The following is a description of a gene set: Any process that modulates the frequency, rate or extent of the assembly of actin filaments by the addition of actin monomers to a filament. species: Homo sapiens Human Gene Set: GOBP_REGULATION_OF_ACTIN_FILAMENT_POLYMERIZATION, and this is the list of marker genes: ELN, SPTBN2, BBS4, CYFIP1, SCIN, CDC42EP1 (CDC42 effector protein 1), FLII, MYADM, TENM1, EVL, CYFIP2, TMOD1, FCHSD2, CAPZA2, ADD2, KANK1, SNX9, DMTN, TWF2, NCKAP1, RAC1, BIN1, ABITRAM, NPHS1, PLEKHG2, ESAM, RASA1, TRIOBP, HCK, BAG4, HCLS1, FER, SSH2, CORO1A, ARHGAP28, CDC42EP2 (NCBI Gene Id 10435), ARPC5L, TMSB4X, MKKS, CAPZB, HIP1R, CAPZA1, NCK2, SPTBN4, SVIL, PRKCD, ARHGAP18, SPTBN1, CCR7, SSH1, MTOR, CARMIL1, LATS1, TWF1, HAX1, CCL26, BAIAP2L2, NCKAP1L, CCL24, ADD3, PFN2, TMOD4, NCK1, CCL21, LMOD3, WASHC2C, SLIT2, PYCARD, KANK4, LMOD1, CYRIB, GBA2, CRACD, ARF6, ARPC5, MTPN, PFN1, C15orf62, CARMIL2, BAIAP2L1, SSH3, VIL1, TMOD3, ARPC2, TMOD2, ARPC3, EPS8, RDX (radixin), CFL1, LMOD2, CAPG, ALOX15, FCHSD1, VASP (NCBI Gene Id 7408), MIR214, DAAM2, CYRIA, VILL, PTK2B, CSF3, GSN, CAPZA3, GRB2, RICTOR (NCBI Gene Id 253260), PIK3R2, CDC42EP3, CTTN (NCBI Gene Id 2017), AVIL, PREX1, KANK3, DLG1, SPTBN5, PAK3, KIRREL1, ASB2, SPTAN1, ADD1, MLST8, COTL1, BAIAP2, SPTA1, CDC42EP5, ARHGAP40, PRKCE, CDC42EP4, CCL11, PFN3, SPTB, ARFGEF1, KANK2